The following is a description of a gene set: species: Homo sapiens Human Gene Set: YRCCAKNNGNCGC_UNKNOWN from publication Xie X, Lu J, Kulbokas EJ, Golub TR, Mootha V, Lindblad-Toh K, Lander ES, Kellis M (PMID 15735639) Comprehensive identification of all functional elements encoded in the human genome is a fundamental need in biomedical research. Here, we present a comparative analysis of the human, mouse, rat and dog genomes to create a systematic catalogue of common regulatory motifs in promoters and 3' untranslated regions (3' UTRs). The promoter analysis yields 174 candidate motifs, including most previously known transcription-factor binding sites and 105 new motifs. The 3'-UTR analysis yields 106 motifs likely to be involved in post-transcriptional regulation. Nearly one-half are associated with microRNAs (miRNAs), leading to the discovery of many new miRNA genes and their likely target genes. Our results suggest that previous estimates of the number of human miRNA genes were low, and that miRNAs regulate at least 20% of human genes. The overall results provide a systematic view of gene regulation in the human, which will be refined as additional mammalian genomes become available. Genes having at least one occurrence of the highly conserved motif M156 YRCCAKNNGNCGC in the regions spanning 4 kb centered on their transcription starting sites. The motif does not match any known transcription factor binding site., and this is the list of marker genes: DUSP10, KCNB2, GRIK3, NOL11, PEX5L, HOXA6, MYCL, KAZALD1, FBXO5, HCRTR1, FLNA, HOXA2, DNAJC11, PSIP1, CLDN1, FZD5, FUCA1, NOP53, PTGES3 (prostaglandin E synthase 3), GRIN2A, SGIP1, SYT6, ZNF341, MAG, RASAL2, ACBD4, TSC22D3, HES1, DHCR24, RND2, GNAS, DNAJC22, CHN2, AARS2, HR, KIF1B, PIGO, DYNLL1, RAB3IP, GAD1, FRS3, DLL4, PATZ1, CRBN, HHEX, SRSF6, ELAPOR1, PTPRF, BHLHE22, UBE2D3, WNT1, CAMTA2, TCERG1L, SCAF8, NR6A1, MAGIX, DCTPP1, CDK5R2, AGO1, PTPRE, GADD45B, ADGRB2, EVA1C (NCBI Gene Id 59271), LHX2, POU2F1, PRICKLE4